The following is a description of a gene set: Synaptic adhesion-like molecules Human Gene Set: REACTOME_SYNAPTIC_ADHESION_LIKE_MOLECULES species: Homo sapiens, and this is the list of marker genes: DLG3, PTPRS, GRIN2B, PTPRD, DLG4, RTN3, GRIN1, GRIN2A, DLG1, GRIA4, LRFN3, LRFN1, LRFN2, LRFN4 (NCBI Gene Id 78999), GRIA1, FLOT2 (flotillin 2), PTPRF, GRIN2C, GRIA3, GRIN2D, FLOT1